The following is a description of a gene set: Any process that stops, prevents or reduces the frequency, rate or extent of chromatin organization. studied in species Mus musculus Mouse Gene Set: GOBP_NEGATIVE_REGULATION_OF_CHROMATIN_ORGANIZATION, and this is the list of marker genes: Samd1, Phf8, Dnmt3l, Kmt2a, Kdm1a, Dyrk1a, Rlf, L3mbtl3, Phf2